The following is a description of a gene set: Mouse Gene Set: GOBP_CLATHRIN_COAT_ASSEMBLY studied in species Mus musculus The process that results in the assembly of clathrin triskelia into the ordered structure known as a clathrin cage., and this is the list of marker genes: Caly, Nsg2, Hip1, Dnm1, Syt11, Fcho1, Ap1b1, Dnajc6, Picalm, Epn1, Snap91, Gak, Gas7, Nsg1, Eps15, Clint1, Clta (NCBI Gene Id 230110), Fcho2, Dab2, Hip1r (huntingtin interacting protein 1 related), Cltc, Ap2b1